The following is a description of a gene set: Human Gene Set: chr6q27 studied in species Homo sapiens, and this is the list of marker genes: DACT2, KIF25, RNU6-730P, LINC00602, ENSG00000309148, ENSG00000289090, ERMARD, LINC02487, GPR31, ENSG00000286674, ENSG00000299106, PSMB1, WDR27 (WD repeat domain 27), KIF25-AS1, ENSG00000271820, MIR1913, HPAT5, PDE10A, RPL12P23, LINC01624, FRMD1, CTAGE13P, THBS2-AS1, RNA5SP226, ENSG00000233365, DYNLT2 (NCBI Gene Id 6991), GNG5P1, RPS6KA2-IT1, RPS6KA2, VTA1P1, MIR4644, GAPDHP72, MPC1, THBS2, TCP10L3, LINC00574, UNC93A, CCR6, LINC02538, TBP, ENSG00000306494, SMOC2, MPC1-DT, SFT2D1, RNASET2, HNRNPA1P49, CEP43, ENSG00000269155, RPS6KA2-AS1, C6orf120, AFDN, TBXT, MIR3939, FAM120B, ENSG00000286760, RPL23AP47, PHF10, LINC02519, ENSG00000229720, TCP10L2, ENSG00000230960, ENSG00000297227, RAMACL, PDCD2, TTLL2, WBP1LP8, RNU6-153P, ENSG00000308986, ENSG00000287189, OR4F7P, LNCDAT, LINC00242, AFDN-DT, DLL1, PRR18, LINC01615, C6orf118